The following is a description of a gene set: from publication Ochiai K, Maienschein-Cline M, Simonetti G, Chen J, Rosenthal R, Brink R, Chong AS, Klein U, Dinner AR, Singh H, Sciammas R (PMID 23684984) Human Gene Set: GSE46606_IRF4HIGH_VS_WT_CD40L_IL2_IL5_DAY1_STIMULATED_BCELL_UP species: Homo sapiens Genes up-regulated in CD40L and IL-2 IL-4 IL-5 stimulated at day 1 B cell IRF4high versus CD40L and IL-2 IL-4 IL-5 stimulated at day 1 B cell wildtype. Temporal analysis of B cell activation in vitro using CD40L and IL-2/4/5 cytokines in wild type Irf4+/+ B cells or in mutant Irf4-/- B cells harboring a tet-inducible allele of Irf4. IRF4 expression was restored, or not, in the Irf4-/- background by culturing in the presence of low or high concentrations of doxycycline. The results provide insight in the role of IRF4 expression levels in coordinating different programs of B cell differentiation., and this is the list of marker genes: GALC, TMT1A, ARID1B, SHLD1, METTL27, UBE2E3, ORAI3, RPL18A, PDE3B (NCBI Gene Id 5140), POMT1, TNRC18, B3GLCT, ZNF571, RPS11, KIFC3, TCF7L2, CENPB, ZDHHC14, PREB, PINK1, APLP2, ACD, INPP5E, RANBP9, RPS7, CREG1, CD300LD, FLI1, SNRNP200, RABEP2, FLYWCH1, CENPO, ABCD4, BBS2, ITPR2, CSTPP1, CTPS2, ZKSCAN8, ADCY7, RPS3, C15orf61, GTPBP3, FAM120C, MATK, TOP3B, FAAP100, ITGB1BP1, HPGDS, ALDH9A1, NAT9, CSNK1E, NAGA, TBC1D22A, TACC3, OSGIN1, ZNF2, ARF3, CDT1, LPGAT1, TCF12, CLN6, FAM76A, CCM2, RPL18, AATK, SLC30A5, MCM7, ZNF839, CCP110, TLE5, RAB7A, TRAPPC12, AP2A2, UROD, CAPZB, PLD4, MRTFA, PABIR2, APEH (acylaminoacyl-peptide hydrolase), NPRL2 (NPR2 like, GATOR1 complex subunit), INPP1, ATP6V0E1, KBTBD3, SYNGR1, CPPED1 (calcineurin like phosphoesterase domain containing 1), GALNT1, CHST12, OXR1, GPR137, HACL1, ANKRD26, TRIM68, THOP1, TCTN3, NAT8L, N4BP2, ING2, GOLGA1, ZNF707, SCMH1, ACVR2B, ALG1, SLC66A1, ANKRD46, RNF169, ARHGEF6, DARS2, EIF2AK4, TBC1D16, PHKA2, NIPAL3, RAB11FIP3, ZKSCAN4, PANX1, RAP2A, STIM1, ZNF566, GLCE, SLC5A6, TTLL1, NSUN4, SENP2, DPY19L4, SNX33, SLC26A6, PPP5C, TTF2, ETFDH, TMEM126B, ERCC6L, TXNDC16, NASP, UBQLN2, GDI2 (GDP dissociation inhibitor 2), ZBTB4, RNF26, FYCO1, FCHSD1, FAM98C, KLHL17, CMC2, TMEM234, C2orf49, SLC35C1, TMEM175, BCAS2, SHPRH, TCF3, MRPL28, SPART, HEXA, TPD52, ZRANB3, ZNF124, CSGALNACT2, SSBP3, CEP170, ACSS2, CTTNBP2NL, CIPC, LMBR1, BTBD1, TEC, ZNF629, SS18, KIF13A, ZDHHC7, SFT2D2, POGLUT2, MEA1, BMPR2, KCTD13, TRRAP, TMEM203, SYPL1, CCDC47, DDHD2, TMLHE, DEPTOR, DUSP22, MBD3 (NCBI Gene Id 8931), ERBB3, SGK1, NBN, KDM2B, FAM234B, TUBGCP6, CDC14B, IDE, RUFY1, MTIF2, ENTPD6, ABHD14B, C16orf54, PPP1R21, ABHD8, NDUFS1, ANXA11 (annexin A11), ATRX, AGFG2